Given this list of marker genes Gab1, Hrg, Igf1, Atp2b4, Sox18 (NCBI Gene Id 98938), Angpt2, Angpt4, Hmox1, Abl1, P2rx4, Map3k3, Nfe2l2 (NCBI Gene Id 98874), Gata2, Ptgs2, Map2k3, Itgb1, Hdac9, Ehd4, Prkd1, Sirt1, Gpld1, Pdcd10, Srf, Spred1, Nus1, Sp1, Micall1, Cxcl12, Gadd45a, Dll4, Mia3, Amot, Plg, Egr3, Rhoa, Mecp2, Col18a1, Vash1, Grem1, Akt3, Pik3r3, Adam8, Ets1, Vhl (von Hippel-Lindau tumor suppressor), Pparg, Cd40, Amotl1, Igf2, Slit2, Fgf2, Prkd2, Angpt1, Nr4a1, Tmsb4x, Myh9, Ctnnd1, Srpx2, Gpx1, Hmgb1, Pik3r2, Nrp1, Mef2c, Meox2, Map2k5, Plk2, Efnb2, Prl7d1, Notch1, Apoe, Adtrp, Hdac5, Robo1, Cxcr4, Tgfbr3, Tgfb1, Prcp, Anxa1, Tbxa2r, Acvrl1, Mmrn2, Emp2, Jup, Atp5f1a, Efna1, Hspb1, Ptk2b, Fbxw7, Pacsin2, Alox12, Vegfa, Pdgfb (platelet derived growth factor, B polypeptide), Fgfr1, Robo4, Pdpk1, Fgf18, Clec14a, Cyp1b1, Akt1 (NCBI Gene Id 268604), Lemd3, Stat5a, Stard13 (StAR related lipid transfer domain containing 13), Cdh5, Sh3bp1, Tnf, Plcg1, Adam17, Prl2c2, Pik3c2a, Hdac7, Foxc2, Atp5f1b, Nr2e1, Itgb1bp1, Card10, Nos3, Prkca, Fgfbp1, Rgcc, Thbs1, Mmrn1, Nf1, Epha2, Kdr, Ephb4, Csnk2b, Jcad, Cln3, Cib1, Scarb1, Klf4, Hif1a, Rhoj, Vegfc, Apoa1, here is a description of the gene set: Mouse Gene Set: GOBP_BLOOD_VESSEL_ENDOTHELIAL_CELL_MIGRATION The orderly movement of an endothelial cell into the extracellular matrix in order to form new blood vessels during angiogenesis. species: Mus musculus